Given this list of marker genes DLL4, NOTCH2NLA, HES5, PSENEN, JAG2, PSEN1, EP300, UBB, MDK, NEURL1, GZMB, MAMLD1, CNTN1, NOTCH2NLB, JAG1, MAML1, RPS27A, NCSTN, NEURL1B, APH1A, UBA52, MAML3, CREB1, APH1B, PSEN2, UBC, RBPJ, HES1, DLL1, ADAM10, MIB2, NOTCH2NLC, MIB1, NOTCH2 (NCBI Gene Id 55574), FCER2, MAML2, here is a description of the gene set: Signaling by NOTCH2 Human Gene Set: REACTOME_SIGNALING_BY_NOTCH2 species: Homo sapiens